Given this list of marker genes TSPO, CXCL11, LPAR3, STC1, AKAP6, BDKRB1, ADCYAP1R1, LACRT, CX3CL1, F2R, HAP1, CCL4, CAV1, UCN, VMP1, XCL1, STIMATE, ORAI1, APLNR, TRPV2, TRPC6, MIR1-1, GRIN1, GPER1, P2RX4, GCG, G6PD, CXCL12, PLA2G1B, STAC3, SRI, CACNB3, CXCL9, CASK, STRIT1, CCL3, PDGFB, TRPC1, ATP2B1, HTT, ATP2A1, PLCG1, P2RX3, MCHR1, CAMK2A, F2RL3, NIPSNAP2, CREB3, GSTO1, ABL1, CAPN3, CRH, CASQ1, F2, MS4A1, STIM2, SNCA, CASR, WFS1, IL13, STIM1, ANK2 (NCBI Gene Id 4028), STAC, P2RY6 (pyrimidinergic receptor P2Y6), CACNB2, CEMIP, LILRA5, AKAP5, P2RX2, ATP2C2, LILRA2 (leukocyte immunoglobulin like receptor A2), CACNA1D, CCR1, PDPK1, ASPH, CCL2, PPP3R1, P2RX5, TOR2A, ISL1, CXCR3, HCRT, CCL5, BAX, THY1, PPP3R2, CRACR2A (calcium release activated channel regulator 2A), P2RX1, PPP3CB, PPP3CC, LGALS3, PPP3CA, NTSR1, HOMER1, WNK3, DRD1, MYLK, STAC2, PDGFRB, GRM6, CXCL10, CD19, FFAR1, BAK1, TRPV3, TRPC3, P2RX7, JPH2, NPSR1, CD4, here is a description of the gene set: Human Gene Set: GOBP_POSITIVE_REGULATION_OF_CALCIUM_ION_TRANSPORT species: Homo sapiens Any process that activates or increases the frequency, rate or extent of the directed movement of calcium ions into, out of or within a cell, or between cells, by means of some agent such as a transporter or pore.